Given this list of marker genes MMP1 (matrix metallopeptidase 1), GRIN2A (NCBI Gene Id 2903), LRBA, MEX3D, CLEC5A, PROS1, SLAMF7, MAGEA8, CXCL10, F2RL3, TMEM140, SPP1, GRM6, NCF4, STK10, STBD1, PCLAF, PLBD1, ANGPT1, ZNF426, NR5A2, MRPL24, NDST2 (N-deacetylase and N-sulfotransferase 2), LAT2, UGGT1, CTSL, SEPTIN9, VSIG4, VWA8, UBE2H, LTA4H, PRPH2 (NCBI Gene Id 5961), RAP1GDS1, SIK3, GAL3ST4, STIMATE, THRB, MICA, VCAN, STARD5, RNF19B, IFIT3, SLCO4A1, HMGCS2, CCNA1, KIF18B, CAPN2, ZFX, EHD4, PSCA, STX5, CD14, PSENEN, ICAM4, PRPF3, PLEK2, RIGI, RELA, CGGBP1 (NCBI Gene Id 8545), SCMH1, RAD51AP1, ERC2 (NCBI Gene Id 26059), CPE, HCG4, DOC2B, FCAR, PLS3, TNFSF13, KCTD15, NR2F1, NDUFB11, TRIM25, COMMD10, ARL8B, AMPH, HROB, PTGDS, RNFT1 (NCBI Gene Id 51136), MAP2K3, MFAP5, RND1, AMN, ABTB2, TPP1, RAB27B, TGFBR3, CDC20, GPR132, SYTL2 (NCBI Gene Id 84564), OCRL, ERGIC3, NCF1C (NCBI Gene Id 654817), IL1B, ROCK2, DTX4, ADM, NNT, TNNT3, RGS16, PEX13, EDN1, KLHL7, VKORC1, B3GNT2, PAPSS2, ASRGL1, MARK1 (microtubule affinity regulating kinase 1), INCENP, SRPK3, HCN2, OPCML, STAT2, CCNJ, CXCL6, TUBA3D, UCHL3, MSR1, CEP55, KCTD20, IFIT2, ACOT11, NUMB, TRIP4, CCL4, CUBN (NCBI Gene Id 8029), SLC7A9, HTRA1, MCMBP, ALOX5, EZR, PFKFB3, TRAF3IP2, PRC1, ADRB2, EPHA5, MOCS3, PPFIA2, MSRA, ADAM10, NEIL1, KIR3DL3 (NCBI Gene Id 199712), MAP1LC3C, XK, HIVEP2, SSTR2, TENT5A, TSPAN7, ADORA2B, PANX1, KMO, KCNJ5 (NCBI Gene Id 3762), MYOZ3, NDUFA4, GNG12, SLN, CTSG, GBP2, CD36, ZWINT, CDK4, SHCBP1, P2RX7, LSS, PLA2G1B, GCNT2, ME3, MAGT1, DHCR24, SEZ6L2, GTF2B, CKB, CENPM, DUSP5, ZC3HAV1, TAS2R1, FCGR1A, DLGAP5, TNC, HPSE, APOBEC3B, GREM2, RRBP1, MAFB, RHBG, DUSP9, RBM4, CHD5, HMGB3P1, FCN1, CYBB, RABGEF1, MMP2, PPBP, RPL21, UBXN8, CAPNS1, NDP, P4HB, FAXDC2, here is a description of the gene set: In the present study we used Affymetrix oligonucleotide microarrays to produce gene transcription profiles for the major leukocyte types in humans. This comprehensive dataset enabled us to not only establish which genes were expressed in each leukocyte type, but also which genes were expressed in each subset after activation. The used of a comprehensive dataset of gene profiles from all the major human leukocyte subsets enabled a novel and powerful means for identification of genes associated with single leukocyte subsets, or different immune paradigms. Genes down-regulated in comparison of dendritic cells (DC) stimulatd with LPS (TLR4 agonist) at 48 h versus macrophages stimulated with LPS (TLR4 agonist) at 4 h. studied in species Homo sapiens from publication Jeffrey KL, Brummer T, Rolph MS, Liu SM, Callejas NA, Grumont RJ, Gillieron C, Mackay F, Grey S, Camps M, Rommel C, Gerondakis SD, Mackay CR (PMID 16474395) Human Gene Set: GSE3982_DC_VS_MAC_LPS_STIM_DN